The following is a description of a gene set: from publication Yu M, Li G, Lee WW, Yuan M, Cui D, Weyand CM, Goronzy JJ (PMID 22434910) Human Gene Set: GSE36476_YOUNG_VS_OLD_DONOR_MEMORY_CD4_TCELL_40H_TSST_ACT_UP With increasing age, the ability of the immune system to protect against recurring infections or to control chronic infections erodes. The objective of the current study was to identify gene expression signatures in elderly CD4 T cell responses studied in species Homo sapiens Genes up-regulated in comparison of memory CD4 T cells from young donors treated with TSST at 40 h versus those from old donors treated with TSST at 40 h., and this is the list of marker genes: MAGEC2, CD8A, SKA1, NR0B2, NPHS1, SLC1A1, PREX2 (NCBI Gene Id 80243), BAALC, KRT34, GRM3, CRABP2, HTR1E, PI15, JAK3, OPRK1, ADGRB3, GCNT3, HOXD1, SSR1, AUTS2, NRIP2, ROBO4, CD93, CPA2, MPPED1, RARB, MAPK4, N4BP3, PROM1, GPR63, B3GNT4, OR2W1, ZSCAN12, PPBP, TMEM209, CRHR1, PMP2, KRT20, XRCC5, HIGD1B, HSF2BP, NRDE2, FFAR2, ZNF646 (zinc finger protein 646), TTLL7, REPS2, ATF4, CACNA1H, DGCR5, SHMT1, YWHAB, EPM2A, CYBB, RAB8A, COL19A1, ELN, RFX4, SERPINA3, WT1, IL1RAPL1 (interleukin 1 receptor accessory protein like 1), SPIB, XIAP, SP1, SLC7A10, MYL3, RPL38, DTX4, HIF3A, CNKSR1, RPL23, APCS, AVPR2, MC2R, SLC6A15, SLC2A9, ATP6V0D1, ERAP2, SCUBE2, KLK7, RANBP17, CBFA2T3, ASAP3, DYRK3, TAS2R3, ZNF215, HMGA2, GUCA1B, MOXD1, ABI3BP, TMED2, REEP4, SYNCRIP, PDE1A, CUBN, TAS2R13, CGREF1, C11orf16, GFER, SORD, CACNA1C, BMP7, RHOBTB3, PHF24, ARSD, ASH1L, NR1I3, SDC1, MAGEC3, SPRY4, ACKR1, KLK10, OR2H2, RAC1, RIPPLY3, OAS2, MALL, IGF1, GNRHR, ASPA, ALPK3, ITIH2, MARCO, RSAD2, P2RX1, PPP1R9A, DNAJC11, FOXC1, MN1, TSPO2, AGMAT, BCAT1, ESRRA (NCBI Gene Id 2101), MYCT1, ATG16L1, CFAP69, GABRR2 (gamma-aminobutyric acid type A receptor subunit rho2), SLC24A3, ZBBX, ARL4D, GPRIN2 (G protein regulated inducer of neurite outgrowth 2), TFF3, HP, MLXIPL, CRYGD, PTPRN, BTK, HYAL1, GABRA2, OLFML3, UNC93B1, UNC5C, KLK14, AGR2, GJA9, ZNF22, APLP1, LILRA4, BCL11A, CYP2A13, NXF2 (nuclear RNA export factor 2), UCHL1, CWH43, EPPIN, MTARC2, RPS24, ITGBL1, SPARC, LIFR, EPS15L1, OVOL2, DNAJB5, COL8A2, PCDHGA11, NEU2, C1QL1, GUSBP11, BTNL2, ADIPOQ, OR51E2, NONO, BRCA2, MCF2, ITGAX, SLC13A3, GML, MYH11, APBA1, ICAM5 (NCBI Gene Id 7087), SMG7-AS1, MAP1LC3C, PLPP2, GFPT2, TRIM45, SIRPA, TMEM151B